Given this list of marker genes Tax1bp3, Ahi1, Prkcz, Cdc42, Gbp4, Otud7b, Fyn, Ddx39a, Pard6g, Celsr2, Oxct1, Ensa, Pla2g4e, Sun5, Ucp2, Fbxw7, Abhd17c, Apoe, Stim1, Midn, Pgap1, Nsfl1c, Fis1, Tfrc, Erbb2, Cct3, Cln3, Dok7, Ins1, Ppm1f, Ptpn23, Fzd9, Ank3, Cela2a, Epb41l1, Fez1, Itgam, Adcy10, Abcg1, Gbf1 (NCBI Gene Id 73518), Traf7, Malrd1, Sptbn1, Yap1, Dlg4, Ano1, Rhbdd3, Ldlrap1, Borcs5, Ripor1, Mecp2, Il6, Atp9a, Ralgapb, Tmbim6, Hectd1, Glud1, Rbm22 (RNA binding motif protein 22), Nedd4l (NCBI Gene Id 83814), Oaz3, Arf1, Casr, Kcnb1, Irs1, Prkd1, Drd3, Cplx1, Pdcd5-ps, Pik3r1, Brca1, Cd81, Ppfia1, Sri, Ice1, Ufl1, Yod1, Sgk1, Rufy3, Egf, Rbp4, Csnk1e, Hadh, Rock2, Neto2, Sin3a, Inpp4b, C2cd5 (NCBI Gene Id 77314), Mir130a, Prkcd, Kalrn, Dab2, Prr5l (NCBI Gene Id 74608), Snca, Mycbp2, Epha2, Rfx3, Mylk2, Nr1h4, G6pc2, Coro2b, Mmd2, Pecam1, Flna, Mrln, Iqgap1, Nsun2, Commd1, Uaca, Sesn2, Slc30a1, Srebf1, Cacna1e, Pde3b, Ppid, Pde4c, Chp2, Cdk5r1, Tert, Anp32b, Cep72, Vti1b, Tmem184a, Map2, Zdhhc5, Ttc21b, Fermt1, Cct8, Ucn3, Ipo5, Cwh43, Dsg2, Arv1, Macroh2a1, Dvl1 (dishevelled segment polarity protein 1), Epb41l5, Pdpk1, Cd2ap, Ramp3, Yipf5, Rbm4, Ifnb1 (interferon beta 1, fibroblast), Gas1, Naca, Swap70, Cep192, Zfp384, Hm629797, Mrap2, Drd4, Cnpy4, Clip3, Cltc, Adcy8, Kcnq1, Rnf168, Mcu, Il13, Lrp5, Ptpn22, Tardbp, Tex15, Rnf4, Xbp1, Insig1, Adcyap1r1, Nr1h3, Derl3, Rack1, Csk, Cemip, Tbc1d20, Tmem53, Pim3, Cenpq, Dzip1, Nf2, Rap1a (RAS-related protein 1a), Reep1, Jak2, Uts2, Atp13a2, Pcnt, Cep135, Ptgs2, Derl2, Neo1 (NCBI Gene Id 78386, neogenin), Cnih2, Cdkn2a, Pln, Bnip3l, Ehd2, Vcp, Vip, Il1a, Epha5 (Eph receptor A5), Tmem98, Ndfip2, Rab29, Crocc, Rapgef3 (Rap guanine nucleotide exchange factor (GEF) 3), Ddx4, Nolc1, Ttn, Bves, Trappc12, Reep6, Vps11, Traf6, Ctsd, Rab11fip5, Stk11, Sumo3, Mup1, Sh3glb1 (SH3-domain GRB2-like B1 (endophilin)), Mup2, Ephb2, Il12b, Pid1, Ncbp2, Stxbp4, Dctn1, Dclk3, Grin2a, Actr3, Nefh, Stac3, Adcy5, Gsk3b, Ubxn2b, Abhd17a, Ins2, Ttbk2, Wasl, Mtnr1a, Eipr1, Cacnb4, Iws1, Wrap53, Gpc3, Jup, Abhd17b, Tor1a, Btf3, Trp53inp2 (NCBI Gene Id 68728), Uhmk1, Cpt1a, Trim50, Vsnl1, Cacng2, Crhr2, Oaz1, Pgrmc1, Myt1, Nckap1, Cep120, Nucb1, Wnt3a, Tmbim1, Sar1a, Dnajb6, Gas8, Mapk14, Dpp10 (NCBI Gene Id 269109), Dclk1, Ffar3, Chmp3, Gnl3, Nmd3, Zfp36l1, Amotl2, Nrde2, Stx3, Arfip1, Larp7-ps, C9orf72, Wdpcp, Magi2, Agtr2, Osbp, Ppp1cc, Gnai1, Ssh1, Camk2d, Slc5a3, Parl (presenilin associated, rhomboid-like), Grip2, Mdm2, Apbb1, Ubr5, Klf7, Nadk, Prkcq (NCBI Gene Id 99373), Nkx6-1, Acvr1c, Prkci, Cacnb3, Zfand1, Akt1, Trim30d, Camk2n1, Cav2, Sfrp1, Gnao1, Crh, Gja1, Scp2, Shh, Mapk1, Cenpj, Tmem108, Sumo1, Cd247, Hras, Cdk5rap3, Frat2, Nr1h2, Lhcgr, Ffar2, Vhl, Kif5b, Lamtor1, Tm7sf3, Tnnt2, Atp2b4, Gpc2, Trim8, B3gat3, C1qtnf12, Rab11b, Tgfb1, Golph3, Slc30a8, Kcne1 (NCBI Gene Id 16509), Acsl4, Alkbh5, Bcl2, Trpa1, Ptbp1, Inpp5e, Gcc2, Agr2, Thoc5, Xirp2, Clasp2, Myo5a, Lmx1b, Apod, Mapt, Hdac3 (NCBI Gene Id 15183), Astn2, Cfl1, Abca12, Mark4, Lamtor5, Parp1, Rptor, Ptch1 (NCBI Gene Id 77214), Hpca, Larp7, Zic1, Drd2, Actb (NCBI Gene Id 11476), Dnajc13, Ccdc88a, Syt11, Tnfaip6, Sik3, Stac2, Limk2, Atg7, Tmed10, Oaz2, Cacna1c, Celsr3, Nptn (NCBI Gene Id 20320), Ppp1r12a, Snx27, Trpc1, Nsd2, Gnl3l, Tcirg1, Baiap3, Pias1, Notch4 (notch 4), Eps15, Anxa1, Dhx36, Ormdl3, Gpc5, Cct6a, Pkdcc, Wls, Meak7, Nup214, Gsk3a, Pmaip1, Wnt8a, Slc25a22, Lrig2, Serp1, Rangrf, Kcnab2, Ywhag, Hdac6, B9d1, Cabp1, Oprm1, Sycp1, Crkl, Fermt2, Frrs1l, Rhot1, Bag4, Ctnna1, Sox4 (SRY (sex determining region Y)-box 4), Gpc6, Plk3 (polo like kinase 3), Supt6, Setd2, Trim29 (NCBI Gene Id 76249), Tgfb2, Map2k2, Lilrb4b, Dennd10, Ctnnd1, Ergic3, Chp1, Cav1, Slc2a2, Gck, Agap2, Lzts2, Cdk9, Cldn18, Hap1, Rab21, Gpsm2, Wwtr1, Nol3, Pcsk9, Rhbdf2, Sybu, Fga, Dvl3, Htt, Dnaja1, Slc35d3, Ccn3, Edem1, Tlr4, Ang (angiogenin, ribonuclease, RNase A family, 5), Trpm5, Tunar, Cep290, Tcp1, Acsl3, Rapgef4, Lgals3, Lztfl1 (leucine zipper transcription factor-like 1), Ndrg4, Synj2bp, Nlgn1, Trpc3, Cask, Rhoq, Vrk1, F2rl2, Slc16a1, Prkaa2, Nos2, Myo1a, Edem2, Dzip1l, Lcn2, Tesk1, Pfkfb2, Ilrun, Hrc, Gm14461 (predicted gene 14461), Hnf4a, Bbc3 (BCL2 binding component 3), Ptpn14, Epb41, Aak1, Ywhaz, Ccne1, Numa1, Hnf1a, Dph3, Ptger3, Chga, Nkx3-1, Plk2, Ehd1, Akt2, Ran, Bcl2l1, Anxa2, Itpr1, Src, Arrb1, Sirt4, Lyplal1, Gli3, Camk2b, Ar, Glul, Lrrk2, Wnt5a, Lmna, Actn2, Syt7, Abat (NCBI Gene Id 57428), Mtcl1, Glp1r, Ndfip1, Pdzk1, Sirt3, Pum2, Strit1, Eny2, Cacna2d2, Epha3, Nup153, Iqsec2, Wnk3, Nlgn2, Snap91, Stx7, Myh10, Rap1gds1, Mapk3, Mepce, Trim12c, Bcap31, Pink1, Ang5, Dnajb2, Cd200, Tmem59, Lilrb4a, Sec24a, Jagn1, Gimap5, Ppp3ca, Pck2, Dtx3l, Akap1, Ptpn1, Kcnj6, Gnaq, Adra2a, Trpm2, Septin8, Fbn1, Tmem30b, Camk4, Tomm70a, Ier3, Adam22, Egfr, Vps4a, Ier3ip1, Ndufaf2, Eif3e, Pcm1, Ghsr, Pdx1, Mtmr2, Msn, Syt4, Nfkbia (NCBI Gene Id 18035), Wwp2, Efna5, Rer1, Oga, Lrp2, Bora (NCBI Gene Id 77744), Lypla1, Bax, Fcer1g, Mlc1, Gabarap, P2rx4, Trim28, Bicd1, Vps28, Sidt2, Arhgef5, Trh, Lats1, Epo, Itgb1bp1, Inhbb, Ptp4a3, Myo5b, Ccne2, Cdk16, Pkia, Sstr5, Shank3, Cdh1, Arpc2, Spag5, Nrxn1, Tmem30a, Crebbp, Gsn, Wnk1, Tmem35a, Gper1, Snap25, Stx6, Akap8l, Nmu, Camk1, Rab11fip1, Cd36 (CD36 molecule), C2cd2l, Mief1, Pkp3 (NCBI Gene Id 70182), C1qtnf3, Arhgdia, Pde8b, Kcnn4, Zbed6, Syt9, Trim5, Birc5, Hnrnpm, Grin1, Cd4 (NCBI Gene Id 212762), Mtnr1b, Ccl5, Cct5, Gpc1, Tmem132a, Map4k4, Ffar1, Arhgef16, Cyp51, Frat1, Trem2, Vegfa, Bad, Mmd, Fto (FTO alpha-ketoglutarate dependent dioxygenase), P3h1, Clstn3, Gja5, Glis2, Ezr, Mff (mitochondrial fission factor), App, Ednra (endothelin receptor type A), Mup11, Arhgdig, Prkaca, Rab23, Xpo1, Smo, Rtn4, Rdx, Mark3, Rabgap1l, Itgb1, Kdm1a, Fgg, Cep250, Pfkm, Lrp4, Nup54 (nucleoporin 54), Slc12a2, Vil1, Ndel1, Piwil4, Vamp8, Rab8a, Uqcc2, Ripor2, Numb, Mief2, Clock, Iscu, Tgfb3, Usp8, Polr1a, Nr1d1, Rhbdf1, Plekhm2, Adam9, Mgat3, Pard6b, P2rx7, Dclk2, Pias4, Ppp1r9b, Nup58, Gcg, Gip (NCBI Gene Id 14607), Pfkl, Gpd1l, Txn1, Leprot, Acd, Fgb, Tomt, Sirt1, Hmgn3, Ptprv, Pard6a, Pde1c (NCBI Gene Id 18575), Stx18, Bmal1, Slc51b, Rab14, Plk1, Tomm7, Lcp1 (NCBI Gene Id 52646), Csrp3, Pick1, Inpp5f, Map2k1, Ppp2r5a, Entr1, Ccdc66, Cib1, Ifng, Cdk1, Myh9, Rac1, Dmtn, Gpm6b, Tenm1, Cyld, Igf1, Lrrc8a, Cd38, Inpp5k, Tlr2, Xpo4, Ptn, Zdhhc7, Kif20b, Anxa5, Lats2 (NCBI Gene Id 50523), Gpld1, Hnrnpab, Erlec1, Idua, F2rl1, Adcyap1, Ppia, Ei24, Tnnc1, Maged1, Vcpip1, Hif1a, Bmp4, Khdc3, Gapvd1, Mcrs1, Edn1, Ttc8, BC034090, Prkar1a, Camk2a, Svip, Appl1 (adaptor protein, phosphotyrosine interaction, PH domain and leucine zipper containing 1), Trim17, Prpf4b, Vamp2, Rsad2, Pin1rt1, Sp100, Bard1, F2, Rint1, Trim58, Ifi27, Ddrgk1, Rnf139, Anxa7, Chchd4, Nr0b2, Slc26a4, Vps26b, Nos1, Lepr, Usp7, Cryab, Stxbp5l, Rest, Angpt1, Peg12, Tmed10-ps, Selenok, Map1b, Use1, Cntln, Tnf, Npm1, Erp29, Alox5, Lep, Reep2, Ube2g2, Rab9, Vamp4, Siah3, Tm9sf4, Stx8, Arhgap8, Atcay, Trim30b, Sqstm1, Nf1, Aacs, Thoc2, Srcin1, Tfap2b, Tpr, Gnaz, Adam10, Tbc1d1, Frmd4a, Ngfr, Kcnj11, Csnk2a1 (NCBI Gene Id 12999), Lypd1, Tcf7l2, Trim25, Fnta, Gripap1, Foxa2, Picalm, Park7, Ufm1, Npff, Zfp36, Pin1, Pmfbp1, Arf6, Mdfic, Exoc4, Hfe, Dkc1, Zpr1, Dhx9, Brsk2, Ralgapa2, Pparg, Gprc6a, Abca2, Slc8b1, Tent2, Prkg2, Blk, Rassf5, Ppp3cb, Cpsf6 (cleavage and polyadenylation specific factor 6), Cep131 (centrosomal protein 131), Krt20, Abi3, Cript, Nbea, Trim40, Fam76b, Trim46, Kif2c, Wnk4, Apbb3, Ang2, Lrrc15, 2700049A03Rik, Exph5, Caly, Emd, Hcls1, Tnfrsf1a, F2r, Nvl, Cdh2, Agrn, Ang6, Tyrobp, Lrp1, Tcaf1, Dynll1, Dlg1, Slc9b2, Zdhhc2, Ipo7, Nutf2, Farp1, Cct4, Nnat, Musk, Gipr, Spi1, Fkbp1b, Capn10, Fndc1, Per2, Tmem231, Bsg, Lamp1, Rab38, Sytl4, Snx3 (sorting nexin 3), Sirt7, Dag1 (NCBI Gene Id 13138), Rab11a, Bmper, Rab34, Myo1c, Snx33, Rab11fip2, Epm2a, 4930550C14Rik, Tmed2, Myrip, Hmgcr, Ppard, Tnik, Bag3, Gpr27, Ubac2, Sh3tc2, Gopc, Acacb, Rangap1, Ngdn (NCBI Gene Id 68966), Ppm1a, Sorbs1, Irs2, Pla2g6, Ube2j1, Washc1, Pten, Cacna1d, Myom1, Shisa6, Ogt, Spidr, Nedd1, Slc1a1, Itga3 (NCBI Gene Id 16400), Prnp, Epb41l2, Ptpmt1, Zdhhc1, Parp9, Prkaa1, Nus1, Cep295, Nutf2-ps1, Grip1, Akap5, Rab11fip3, Madd, Dnm1l, Zmynd8, Afdn, Inppl1 (inositol polyphosphate phosphatase-like 1), Prkcb, Mlxipl, Ctnnb1, Mesd, Mup3, Adipoq, Gnas, Vps35 (NCBI Gene Id 65114), Mrap, Hsp90aa1, Ap2m1, Slc7a11, Pinx1, Zc3h12a, Stac, Agt, Pml, Mup5 (NCBI Gene Id 17844), Ptpn11, Cnr1, Trim30a, Plcb1, Isl1, Cnst, Rhog, Trim30c, Pkp1 (plakophilin 1), Gdi2, Gdi1, Atp2c1, Gna11, Sapcd2, Idh2, Riok2, Tmem97, Fbxo4, Pdcd5, Mmp13, Adtrp, Bglap2, Sec16b, Kif3a, Vcl (NCBI Gene Id 268722), Fam3d, Mtor, Hcfc1, Stom, Chrm3, Tyk2, Trim12a (tripartite motif-containing 12A), Or51e2, Eif2ak3, Ric3, Pkig, Il12a, Eif4g1, Sorbs2, Rsl1d1, Sergef, Nkd2, Abcc8, Ghrh, Nlrp5, Nedd4, Hyal2, Hspa1l, Sirt6, Septin2, Rbm10 (NCBI Gene Id 260306), Wipf1, Khdrbs1, Ptpn9, Stx4a, Ep300, Mpc2, Nedd9, Pard3, Rph3al, Ankrd1, Os9, Cartpt, Shisa7, Dnajc1, Ncoa6, Unc13b, Scfd1, Ankrd13a (NCBI Gene Id 68420), Map1a, Gas6, Ywhab, Vegfc, Abca7, Myo18a, Prkn, Pls1, Mfhas1, Umod, Efcab7, Itgb3, Cct7, Golph3l, Dpp6 (NCBI Gene Id 51817), Bak1 (BCL2-antagonist/killer 1), Mapk8, Prkce, Sorl1, Mir410, Asph, Rfx6, Ptpn5, Tiam1, Pak1, Erbb4, Krt5, Card10, Ang4, Arhgap1, Mavs (mitochondrial antiviral signaling protein), Necab2, Nup62, Atp5if1 (NCBI Gene Id 11983), Usp17le, Six4, Mir200a, Snx12, Atp2a1, Cdk5, Cryaa (crystallin, alpha A), Apc, Nlgn3, Ptger4, Pla2g3, Gpr68, Doc2b, Crk, Sfn, Hcar2, Pik3r2, Ghrl, Chrm1, Foxo1, Ccl2, Mmp14, Il1b, Misp, Icmt, Jak1, Orai1, Tek, Tsg101, Dbn1, Psen1, Ctdspl2, Gimap3, Mtmr4, Pdcd10, Adora2a, Ooep, Six1, Ap2b1, Arhgap44, Nhlrc1, Sec24b, Pcsk1, Mup4, Trpm4, Dsg3, Pik3ca, Dynlt2b, Camk2g, Terf1, Hsp90ab1, Hnrnpk, Ect2, Cct2, Ywhae, Gpr137b, Dync1h1, Psmd9, Dmap1, A1cf, Gpc4, Gpr39, Cftr, here is a description of the gene set: species: Mus musculus Any process that modulates the frequency, rate or extent of a process in which a cell, a substance, or a cellular entity is transported to, or maintained in a specific location within or in the membrane of a cell. Mouse Gene Set: GOBP_REGULATION_OF_CELLULAR_LOCALIZATION